The following is a description of a gene set: species: Homo sapiens Human Gene Set: GOBP_CALCINEURIN_MEDIATED_SIGNALING Any intracellular signal transduction in which the signal is passed on within the cell by activation of a transcription factor as a consequence of dephosphorylation by Ca(2+)-activated calcineurin. The process begins with calcium-dependent activation of the phosphatase calcineurin. Calcineurin is a calcium- and calmodulin-dependent serine/threonine protein phosphatase with a conserved function in eukaryotic species from yeast to humans. In yeast and fungi, calcineurin regulates stress signaling and cell cycle, and sporulation and virulence in pathogenic fungi. In metazoans, calcineurin is involved in cell commitment, organogenesis and organ development and immune function of T-lymphocytes. By a conserved mechanism, calcineurin phosphatase activates fungal Crz1 and mammalian NFATc by dephosphorylation and translocation of these transcription factors to the nucleus to regulate gene expression., and this is the list of marker genes: C10orf71, TNF, ERBB3, SPPL3, CALM2, NFATC2, SLC9A1, ATP2B4, PRNP, NFAM1, CHP2, CALM1, LACRT, AKAP5, NR5A2, PPP3CA, LMCD1, CIB1, AKAP6, MAPK7, PPP3R2, PTBP1, IGF1, EFHB, ACTN3, CALM3, PLCG2, PPP3CC, NFATC4, CHP1, FHL2, NR5A1, DYRK2, ORAI1, PPP3CB, CAMTA1, ADGRB2, PPP3R1, HOMER3, MTOR, NFATC3, SLC8A2, MYOZ2, CLEC7A, NFAT5, RCAN2, GSK3B, TPRG1L, MYOZ1, NFATC1, TBC1D10C, CHERP, RCAN1, HOMER2